The following is a description of a gene set: species: Mus musculus Excision from the chromosome and circularization of a region of chromosomal DNA, generally, but not always, via homologous recombination between direct tandem repeats. Mouse Gene Set: GOBP_FORMATION_OF_EXTRACHROMOSOMAL_CIRCULAR_DNA, and this is the list of marker genes: Xrcc3 (X-ray repair complementing defective repair in Chinese hamster cells 3), Xrcc5, Nbn, Terf2, Slx4, Ercc1, Slx1b, Rtel1